Given this list of marker genes NEK11, PSMC2, CHEK1, SKP1, PSMC6, UBA52, PSMD7, SEM1, BTRC, CHEK2, PSMC4, PSMB4, PSMB5, PSMA4, PSMB2, GSK3B, PSMD1, RBX1, CSNK1A1, PSMD3, PSMB3, PSMD12, FBXW11, PSMA2, UBC, PSMB6, CSNK1E (casein kinase 1 epsilon), PSMD8, PSMC3, PSMB7, PLK3, PSMA1, PSMA3, CUL1, PSMD13, PSMD11, PSMC5, PSMD2, PSMA7, PSMC1, MAPK14, UBB, RPS27A, PSMD14, PSMD6, PSMA6, MAPK11, PSMA5, ADRM1, CDC25A, PSMB1, here is a description of the gene set: part of: G1/S DNA Damage Checkpoints <p>The G1/S arrest induced by DNA damage has been ascribed to the transcription factor and tumor suppressor protein TP53 (p53). To be effective within minutes after DNA damage, induction of the G1/S block should exploit transcription- and protein synthesis-independent mechanisms.</p><p>Upon exposure to ultraviolet light (UV) or ionizing radiation (IR), the abundance and activity of the protein phosphatase CDC25A, required for G1/S transition, rapidly decreases in a p53-independent manner. The rapid ubiquitin- and proteasome-dependent destruction of CDC25A phosphatase prevents entry of a cell into S phase by maintaining the Cyclin E:CDK2 (CCNE:CDK2) and, to a lesser extent, Cyclin A:CDK2 (CCNA:CDK2) complexes in their inhibitory phosphorylated (p-Y15) form. The destruction of CDC25A in response to UV exposure is dependent on CHEK1 (Chk1) activity while CHEK2 (Chk2) contributes to CDC25A destruction in response to IR. For details, please refer to events "Phosphorylation of CDC25A by CHEK1", "Phosphorylation of CDC25A by CHEK2", and "CHEK1 phosphorylates CHEK2-phosphorylated CDC25A". The CDC25A-dependent G1/S arrest is reversible, allowing cells to repair UV-induced DNA damage before the onset of DNA replication.</p><p>The overexpression of CDC25A overrides CHEK1-induced G1/S arrest in vitro and has been reported in a subset of aggressive human tumors.</p><p>CHEK1- and CDC25A-mediated G1/S arrest precedes TP53/CDKN1A (p53/p21)-mediated G1/S arrest.</p> species: Homo sapiens Reactome Pathway: p53-Independent G1/S DNA Damage Checkpoint